Given this list of marker genes Cfap58, Col17a1, Gm25644, Cfap43, Siah1-ps1, Sorcs1, Gm26629, Gm22113, 4930535F04Rik, Sorcs3, Sfr1, Rpl13a-ps1, Gm6975, Gm16068, Gsto1, Itprip, Mir8090, Gsto2, Gm26085, here is a description of the gene set: Mouse Gene Set: chr19D1 studied in species Mus musculus